Given this list of marker genes ATP6V0A1, ATP2B1, ATP1A3, ABCC8, KCNJ8, ATP5F1B, SLC36A1, ATP6V0D1, ABCG4, NDUFC1, NDUFV1, ABCA12, ATP6V1A, ATP8A1, NDUFS8, ABCA7, NDUFB5, ABCC3, NDUFB8, NDUFB3, ATP2A1, ABCC1, MT-ND1, NDUFB4, ABCG2, NDUFS3, NDUFB6, UQCRC1, ABCD4, ABCB9, NDUFA3, ATP6V1E1, NDUFA12, NDUFC2, COX7B, MT-CO3, ATP6V0B, NDUFA5, ABCA3, ABCA6, NDUFA1, ATP12A, COX5B, CFTR, MT-ND6, MT-CO1, ATP6V1H, ABCA10, ATP13A5, ABCB4, ATP7B, ATP2A2, ABCB1, ABCC12, ABCC5, ATP6V1C2, ABCA1, ABCC10, ABCB8, MTCO2P12, ATP6V0D2, ATP2B3, MT-CYB, CYBRD1, ABCA2, COX8A, ABCD2, TOMM20, ATP6V0E1, ATP13A3, NDUFA9, NDUFB10, ATP6V1G1 (ATPase H+ transporting V1 subunit G1), ABCA5, ATP6V1G3, NDUFV2, NDUFS5, ABCG5, CYB561D2, ATP4B, TAP1, ABCC2, ATP6V1C1, NDUFV3, ATP2B2, TAP2, CYB561D1, ATP7A, NDUFA7, ABCB7, NDUFB9, UQCRFS1P1, ATP6V0E2, ATP6V1B2, MT-ND4L, ABCD3, ATP6V1B1, ABCA8 (NCBI Gene Id 10351), UQCR10, ABCC6, COX7A1, ATP6V1F, ABCD1, ABCC9, ATP6V1D, ABCG8, ATP2A3, NDUFS2, SURF1, ABCB11, ATP1A1, MT-CO2, ABCA13, NDUFA6, ATP2C1, NDUFS4, NDUFB2, ATP6V0A2, NDUFA10, CYC1, ATP2C2, ABCB6, ABCA4, ABCA9, ABCB5, ATP1B1, ATP6V1G2 (ATPase H+ transporting V1 subunit G2), ABCG1, NDUFB1, COX4I1, ATP1A4, NDUFS7, KCNJ11, COX5A, ATP13A1, ABCC11, NDUFS1, NDUFA2, NDUFA4, RALBP1, COX7A2L, MT-ND5, ATP1A2, ATP6V1E2, TMEM94, UQCRFS1, ATP13A2, ATP6V0C, COX6B1, NNT (NCBI Gene Id 23530), ATP6V0A4, ATP4A, ATP2B4, MT-ND3, UQCRH, NDUFB7, ATP13A4, ABCB10, NDUFS6, ABCC4, NDUFA8, CYB561A3, MT-ND2, TCIRG1, MT-ND4, here is a description of the gene set: species: Homo sapiens Enables the transfer of a solute from one side of a membrane to the other, up the solute's concentration gradient, by binding the solute and undergoing a series of conformational changes. Transport works equally well in either direction and is powered by a primary energy source. Primary energy sources known to be coupled to transport are chemical such as ATP hydrolysis, redox energy and photon energy. Human Gene Set: GOMF_PRIMARY_ACTIVE_TRANSMEMBRANE_TRANSPORTER_ACTIVITY